The following is a description of a gene set: The process in which a relatively unspecialized cell acquires specialized structural and/or functional features of a thyroid-stimulating hormone-secreting cell. A thyroid-stimulating hormone-secreting cell is a basophil cell of the anterior pituitary that produces thyroid-stimulating hormone, thyrotrophin. studied in species Homo sapiens Human Gene Set: GOBP_THYROID_STIMULATING_HORMONE_SECRETING_CELL_DIFFERENTIATION, and this is the list of marker genes: BMP2, FGF8, GATA2, FGF2, WNT4, LHX3